The following is a description of a gene set: Human Gene Set: GOCC_TRANSCRIPTION_ELONGATION_FACTOR_COMPLEX species: Homo sapiens Any protein complex that interacts with RNA polymerase II to increase (positive transcription elongation factor) or reduce (negative transcription elongation factor) the rate of transcription elongation., and this is the list of marker genes: ICE1, SUPT6H, SUPT5H, RTF1, ELP2, CDC73, CCNK, SNW1, ELOA, SUPT16H (SPT16 homolog, facilitates chromatin remodeling subunit), NELFE, EAF2, ELOF1, ELL, CDK12, PAF1, LEO1, RB1, AFF2, ERCC6, CCNT1, ICE2, AFF1, SUPT4H1, ELOC, ELL3, ELP4, CDK9, NELFCD, CTR9, NELFA, SSRP1, NUFIP1, MMS22L, PEX2, ELOB, TONSL (NCBI Gene Id 4796), CDK13, MLLT3, MLLT1, TTF2, ELL2, AFF3, ZC3H8, EAF1, CCNT2, AFF4, SKIC8, ELOA2, NELFB, EPOP, TCEA2 (transcription elongation factor A2)